The following is a description of a gene set: studied in species Homo sapiens Compensating for the variation in the unpaired sex chromosome:autosome chromosome ratios between sexes by activation or inactivation of genes on one or both of the sex chromosomes. Human Gene Set: GOBP_SEX_CHROMOSOME_DOSAGE_COMPENSATION, and this is the list of marker genes: HDAC3, YTHDC1, LRIF1, SMCHD1, PCGF5, HNRNPK, CIZ1, PCGF3, SUZ12, CDYL (NCBI Gene Id 9425), RLIM, SPEN, RBM15B, RBM15, HNRNPU, BRCA1, MACROH2A1, KAT8, METTL3, LBR, XIST, JARID2, MACROH2A2